The following is a description of a gene set: Mouse Gene Set: GOBP_NUCLEOBASE_BIOSYNTHETIC_PROCESS The chemical reactions and pathways resulting in the formation of a nucleobase, a nitrogenous base that is a constituent of a nucleic acid. studied in species Mus musculus, and this is the list of marker genes: Cps1, Gart, Hprt1, Prps1, Aprt, Ctps1, Paics, Mtor, Ppat, Ctps2, Cmpk1, Umps, Ada, Shmt1, Cad, Dhodh